The following is a description of a gene set: Genes up-regulated in APL (acute promyeolocytic leukemia) blasts expressing PML-RARA fusion compared to normal promyeloblasts. from publication Casorelli I, Tenedini E, Tagliafico E, Blasi MF, Giuliani A, Crescenzi M, Pelosi E, Testa U, Peschle C, Mele L, Diverio D, Breccia M, Lo-Coco F, Ferrari S, Bignami M (PMID 16990782) studied in species Homo sapiens Acute promyelocytic leukemia (APL) is a clonal expansion of hematopoietic precursors blocked at the promyelocytic stage. Gene expression profiles of APL cells obtained from 16 patients were compared to eight samples of CD34+-derived normal promyelocytes. Malignant promyelocytes showed widespread changes in transcription in comparison to their normal counterpart and 1020 differentially expressed genes were identified. Discriminating genes include transcriptional regulators (FOS, JUN and HOX genes) and genes involved in cell cycle and DNA repair. The strong upregulation in APL of some transcripts (FLT3, CD33, CD44 and HGF) was also confirmed at protein level. Interestingly, a trend toward a transcriptional repression of genes involved in different DNA repair pathways was found in APL and confirmed by real-time polymerase chain reactor (PCR) in a new set of nine APLs. Our results suggest that both inefficient base excision repair and recombinational repair might play a role in APLs development. To investigate the expression pathways underlying the development of APL occurring as a second malignancy (sAPL), we included in our study eight cases of sAPL. Although both secondary and de novo APL were characterized by a strong homogeneity in expression profiling, we identified a small set of differentially expressed genes that discriminate sAPL from de novo cases. Human Gene Set: CASORELLI_ACUTE_PROMYELOCYTIC_LEUKEMIA_UP, and this is the list of marker genes: SPSB3, RAP1GAP2, PER1, IGHG1, TCF7L2, SPRY2, GPR183, ZNF185, FNDC3B, SIN3B, ANKS1A, AUTS2, IGHA1, CTSW, ITM2B, FLT3, HELZ, NR4A2, CD44, STK17B, PLCB1, ZBTB18, DMXL2, ZNF273, DRG1, EVI2A, ATP1B1, JMJD7-PLA2G4B, MGST3, TMEM243, TRIB1, LONP2, IGLC2, STAB1, UBBP1, VAMP1, TLR2, TGOLN2, WDFY3, SND1, ID2, MRPS30, FOSB, ANXA8, TOMM20, IGKV1D-13 (NCBI Gene Id 28902), RGCC, TSC22D3, SMC5, ZNF264, RBMS1, GABRE, CD33, ARL4A, AAK1, TPBG, HAL, HIC2, TMEM131, ST3GAL5, PLAAT3, TCL1A, WASL (NCBI Gene Id 8976), KRT18, CHST11, AFF2, AZI2, S100P, BTG1, CMAHP, NDUFS4, HBEGF, ATP2B4, ABHD3, TCFL5, AP1S2, IGFBP7, NFYA, RPL26P36, ZBTB43, IDUA, ALCAM, SIPA1L1, MRC2, MST1P2, BCL11B, TIMP1, ZFP36, SPEN, MTARC2, CD8A, COL4A5, NDE1, LY75, JUN, FGF13, PTGDS, TOMM7, SIK1, UTP14C, ARHGAP25, PDE3B, MXRA7, XIST, H2AC18, SIK3, MAP1LC3B, SF1, ZMYM2, KAT6B, SLC31A2, FCMR, ATP6V1G1, IRS2, GLRX, CITED2, CEBPD, NLRP1, CCNA1, GFI1, NFIL3, IGKV3-20, NACA, AGTPBP1, HCAR3, GLIPR1, UBE2D4, CFD, CSGALNACT2, SAP30, TANK, FOS, SORL1, NDST2, IGKC, PRKCA, HGF, KLF10, CBLB, ZNF91, RGS2, GNLY, JAG1, ADA2, PTPRE, SMURF2 (SMAD specific E3 ubiquitin protein ligase 2), MED13L, RNF11, KLF6, CFP, DUSP1, PRF1, ZFAND5, SERPING1, PSMA1, MT-ND5, MT1F, ADGRE2, PLEKHA5, NRIP3, CD3D, PLSCR3, ZSWIM8-AS1 (ZSWIM8 antisense RNA 1), MYLIP, DENND5A, H2BC21, PLAGL1, H2BC12, CD96, KLF2, N4BP2L1, MRPL33, NFKBIA